The following is a description of a gene set: Any process that modulates the frequency, rate, or extent of a series of reactions, mediated by the intracellular serine/threonine kinase protein kinase C, which occurs as a result of a single trigger reaction or compound. studied in species Homo sapiens Human Gene Set: GOBP_REGULATION_OF_PROTEIN_KINASE_C_SIGNALING, and this is the list of marker genes: EGFR, HSPB1, AKAP12, DGKQ, CD40